The following is a description of a gene set: Unfolded actins and tubulins bound to prefoldin are transferred to CCT via a docking mechanism. Reactome Pathway: Prefoldin mediated transfer of substrate  to CCT/TriC part of: Cooperation of Prefoldin and TriC/CCT  in actin and tubulin folding species: Homo sapiens, and this is the list of marker genes: CCT6B (NCBI Gene Id 10693), TCP1, CCT4, PFDN4, CCT6A, TUBB4A, PFDN5, TUBB1, CCT5, CCT2, TUBB6, TUBA1A, TUBA3D, CCT7, TUBB2B, TUBB4B, TUBA4A, PFDN2, CCT3, VBP1, TUBA1C, TUBA3C, TUBB2A, PFDN6, ACTB, TUBB3, CCT8, PFDN1